Given this list of marker genes ITPR1, KCTD14, TMEM140, CCSER1, TGFB3, RRM2, TRAK1, BEST2, CYP27A1, EDNRA, ADD3, ZBTB16, FKBP5, MEGF6, NT5DC2, ASB7, NRP1, DDIT4L, SPOCK2, ATP1A1, HPGD, IFIT2, ABCG2, FZD1, CPEB3, DOCK5, DNM3, ANAPC16, TSPAN13, PMM1, EDNRB, BCL2L11, PDE9A, TRIB2, SEMA6A, STC2, NDRG2, GNMT, SCRG1, RAMP3, MYB, LAP3, ACOT6, NR3C1, CCDC71L, GALNT15, FXYD4, ENPP1, COL19A1, TESPA1, ST6GAL1, MGAT4A, SLC43A2, TFAP2E, PARVA, OLIG1 (oligodendrocyte transcription factor 1), LCORL, SULF2, PDGFRA, NTRK2, TTLL7, RASSF9, SLC26A6, CHD9 (NCBI Gene Id 80205), GULP1, IQGAP2, TTC28, SERPINB4, P4HA2, SCNN1G (sodium channel epithelial 1 subunit gamma), TNFRSF21, RAB11FIP5, CMAHP, SPINK2, RECK, IL17RB, here is a description of the gene set: from publication Chebotaev D, Yemelyanov A, Zhu L, Lavker RM, Budunova I (PMID 17146443) Glucocorticoids are potent inhibitors of mouse skin tumorigenesis. The glucocorticoid control of cellular functions is mediated via the glucocorticoid receptor (GR), a well-known transcription factor. Recently, we generated transgenic mice overexpressing GR under control of the keratin5 (K5) promoter, and showed that K5.GR animals are resistant to skin carcinogenesis. Follicular epithelial stem cells (SCs), located in the bulge region of the hair follicle, are believed to be one of the target cells for skin carcinogenesis. We found that the number of putative hair follicle SC detected as label-retaining cells was significantly less in the K5.GR transgenics compared to wild type (w.t.) littermates. We also showed that GR overexpression led to a reduction in the clonogenicity of the follicular epithelial SCs. We evaluated the global effect of GR on gene expression in a population of follicular SC-enriched bulge keratinocytes isolated by fluorescence activated cell sorting. We found that GR affected the expression of numerous bulge SC 'signature' genes, genes involved in the maintenance of SC and progenitor cells of non-epidermal origin and proapoptotic genes. Our findings underscore the important role of GR signaling in the homeostasis of follicular epithelial SCs, and suggest that the reduction in their number may underlie the tumor suppressor effect of GR in the skin. Human Gene Set: CHEBOTAEV_GR_TARGETS_UP studied in species Mus musculus Genes up-regulated in follicular epithelial stem cells after transgenic expression of GR under control of the keratin5 (K5) promoter.